Given this list of marker genes PIK3R1, WDR6, LEMD3, DEPDC1B, CPD, ANKRD26, CKB, KTN1, SCRIB, MUC13, CCDC88A, PLEKHG5, CAV1, ARHGAP21, PIK3R2, DSG1, TMOD3, DST, VANGL2, DDX4, ARHGAP5, CKAP4, PICALM, DLG5, NISCH, RASAL2, KCTD13, EPHA2, ROCK1, UBXN11, FLOT2, TNFAIP1, SEMA4F, TXNL1, PKP4, VANGL1, PTPN13, RND3, RBMX, ARHGAP35, FAM83B, DSP, here is a description of the gene set: Human Gene Set: REACTOME_RND3_GTPASE_CYCLE RND3 GTPase cycle species: Homo sapiens